Given this list of marker genes Bmp6, Prkca, Ptpn11, Ly86, Cd180, Cd14, Sash1, Ly96, Mif, Traf6, Scimp, here is a description of the gene set: studied in species Mus musculus Mouse Gene Set: GOBP_POSITIVE_REGULATION_OF_LIPOPOLYSACCHARIDE_MEDIATED_SIGNALING_PATHWAY Any process that activates or increases the frequency, rate or extent of signaling in response to detection of lipopolysaccharide.